Given this list of marker genes RELA, NFKBIA (NFKB inhibitor alpha), BIRC3, BIRC2, TRAF5, CCL2, CHUK, TNFRSF14, NFKB1, TRAF2, IKBKB, IKBKG, here is a description of the gene set: studied in species Homo sapiens Human Gene Set: KEGG_MEDICUS_PATHOGEN_HSV_GD_TO_HVEM_NFKB_SIGNALING_PATHWAY HSV gD to HVEM-NFKB signaling pathway. Pathway ID: N00560. Pathway type: Pathogen. Pathway class: nt06516 TNF signaling. Pathway Definition from KEGG: GD -> TNFRSF14 -> TRAF2/5 -> IKK -> NFKBIA -> NFKB => (BIRC2,BIRC3,NFKB1,RELA,CCL2)